Given this list of marker genes SIK1, RELB, JUNB, TNC, PLPP3, PNRC1, ATP2B1, EGR3, NR4A1, SPHK1, CXCL3, NINJ1, SERPINE1, SQSTM1 (NCBI Gene Id 94002), CD83, ATF3, TNFAIP3, SLC16A6, BCL3, ZFP36, VEGFA, CEBPB, SMAD3 (NCBI Gene Id 51521), JAG1, CD69, BTG1, TNFRSF9, PLK2, FOSL2, IL6 (interleukin 6), DUSP4, SGK1, LDLR, CXCL10, CCL5, ICAM1, NFKBIA, CSF2, CCL4, MAFF, IL1B, PPP1R15A, PER1, TNFAIP8, TRIB1, PHLDA2, CXCL2, TUBB2A, GFPT2, TNFAIP6, CEBPD, B4GALT5 (beta-1,4-galactosyltransferase 5), NFKB1, IL1A, TGIF1, SOD2, TNFAIP2, ID2, CCL2, RELA, MAP2K3, CCRL2, BTG2, NFKB2, KYNU, ETS2, TRAF1, HBEGF, TNIP2, AREG, GCH1, LITAF, ZBTB10, IL6ST, CCL20, FUT4, RIPK2, PDE4B, CXCL6, IRS2, INHBA, NFKBIE, B4GALT1, LAMB3, YRDC, IFNGR2, DUSP2, OLR1, IER2, CFLAR, REL (NCBI Gene Id 5966), GADD45B, KLF4, STAT5A, TANK, CXCL1, CD44, IRF1, KLF2, FOSB, KLF10, ICOSLG, IER5, PTGS2, TSC22D1, TIPARP, BCL2A1, FOSL1, CCNL1, PLEK, BTG3, PTGER4 (NCBI Gene Id 5734), NFIL3, IL12B, GEM (GTP binding protein overexpressed in skeletal muscle), EGR2, RHOB, SPSB1, IER3, GPR183, IL18, RIGI, MYC, FJX1, PHLDA1, TAP1, DUSP1, EHD1, BIRC3, IL23A (NCBI Gene Id 51561), BHLHE40, PLAUR, SAT1, TRIP10, JUN, IL7R, SERPINB2, ABCA1, BMP2, TNFSF9, EIF1, NR4A2, KLF6, ZC3H12A (zinc finger CCCH-type containing 12A), EDN1, MAP3K8, IFIT2, ACKR3, BCL6, KDM6B, RNF19B, MARCKS, SDC4, LIF, PLAU, PTPRE, SNN, SLC2A6, DNAJB4, SERPINB8 (NCBI Gene Id 5271), FOS, IL15RA, TNF, CDKN1A, NR4A3 (NCBI Gene Id 8013), CCN1, F3, CXCL11, PDLIM5, DRAM1, TLR2, MCL1, EGR1, MSC, BIRC2, EFNA1, DENND5A, NAMPT, RCAN1, G0S2, NFAT5, SOCS3, CSF1, F2RL1, KLF9, PFKFB3, DUSP5, TNIP1, PTX3, CCND1, CD80, PANX1, GADD45A, NFE2L2 (NFE2 like bZIP transcription factor 2), MXD1, SLC2A3, PMEPA1 (prostate transmembrane protein, androgen induced 1), HES1, IFIH1, CLCF1, here is a description of the gene set: species: Homo sapiens from publication Liberzon A, Birger C, Thorvaldsdóttir H, Ghandi M, Mesirov JP, Tamayo P (PMID 26771021) Genes regulated by NF-kB in response to TNF. Human Gene Set: HALLMARK_TNFA_SIGNALING_VIA_NFKB